The following is a description of a gene set: from publication Fiorentini S, Riboldi E, Facchetti F, Avolio M, Fabbri M, Tosti G, Becker PD, Guzman CA, Sozzani S, Caruso A (PMID 18310327) Genes down-regulated in plasmacytoid dendritic cells treated with IL3: HIV matrix protein p17 versus CpG. We used microarrays to detail the global program of gene expression underlying the effect of p17 on human plasmacytoid dendritic cells and was compared to CpG profile. Human Gene Set: GSE10147_IL3_AND_HIVP17_VS_IL3_AND_CPG_STIM_PDC_DN studied in species Homo sapiens, and this is the list of marker genes: CCNJL, MAVS (NCBI Gene Id 78993), IRF2BP2, FMNL3, SNX12, SNRPD3, ANKRD27, ZC4H2, LZTS2 (NCBI Gene Id 84445), UBASH3A, PTPA, EIF4EBP2, TPRG1L, FADS1, FAM234A (NCBI Gene Id 83986), GYPC, PAG1, ENDOD1, USP30, TMEM65, ACTR1A, NAA25, TXNL4B, MRPS26, ADRB2, PDK2, RNF25, CD9, ZMPSTE24, JAK1, RBPJ, P2RX4, RBM22, MINK1, EIF3B, GPAT2, RAVER1, GATAD1, SPEM1, ARHGAP31, UBA1, L1CAM, ARHGAP10, ZFP64, METTL27, SH2B2, MIDN, GPANK1, TRMT10C, RAD52, NEXMIF, MIR216A, ZYG11B, RSF1, RAB3D, CHD4, PRRG4, CFAP263, GADL1, CIAO2B, POLE4, OBI1, CDKN2AIPNL, CEP83, MAGED2, TNF, FRAT1, NEDD4L (NCBI Gene Id 93998), SIN3A, SLC39A1, HEATR6, ACO2, HADH, TTL, SAP130, TAF8, ANKRD29, TBC1D17, MRPL17, SEPHS1, EPHB6, LCK, POR, ATG4B, OTUD5, PDP2, NMT2, NRG4, NEURL3, JRK, GCH1, CD81, RAB11FIP1, SLC39A11, TSEN2, CAND2, PANK1, UBE2Z, MYO10, ALDH2, BTD, PALS2, ARL8A, PDZRN4, SCML4, RCN2, RDH11, MACC1, PDGFC, MED13L, ILF3, FLOT2, IQGAP1, TMEM209 (NCBI Gene Id 84928), STAR, NFYC, PPP1R11, COLGALT1, TEX28, NQO2, CXXC5, RPIA, NADK, MOCS1, HSD17B1, ODF2L, IVL (involucrin), MIR34C, RNF215, TLR3, PTH, TRIM10, RIT1, GOLM1, NPAS2, BRCA2, TUBG1, BMX, IL10RB, ATPAF1, TECR, SAP30BP, TNS1, SYDE2, MEX3B, ADCK1, GRAMD1A, MAP3K3, MAGED1, SRM, KCNA2, JPT1, ST8SIA6